The following is a description of a gene set: A protein glycosylation process in which a carbohydrate or carbohydrate derivative unit is added to a protein via the hydroxyl group of peptidyl-serine, peptidyl-threonine, peptidyl-hydroxylysine, or peptidyl-hydroxyproline, or via the phenol group of peptidyl-tyrosine, forming an O-glycan. species: Mus musculus Mouse Gene Set: GOBP_PROTEIN_O_LINKED_GLYCOSYLATION, and this is the list of marker genes: Tmem260, Slc35c2, Poglut3, Galnt11, Galnt1, Fut9, Tmtc4, Fut11, Tmtc3, B3gnt9, Pomt1, Pomt2, C1galt1c1, St8sia6, Galntl6, B3gnt3, Plod3, Vegfb, B3galnt2, Poglut2, B4gat1, Crppa, Ogt, Tet3, Tet1, B3galnt1 (NCBI Gene Id 26879), B3galt6, Fut10, Galnt2, Gxylt1, A4gnt, B3galt5, Galnt15, Galnt12, B3gnt6, Mgat5b, B3gnt4, Galnt5, Galnt14, Large2, Galnt7, St6galnac2, Gcnt3, Galnt17, Pgm3, Galnt9, Galnt6, Eogt, Pomgnt2, B3gnt2, Large1, Gxylt2, B3gnt7 (NCBI Gene Id 329198), Galnt13, Fkrp, C1galt1, Pofut2, Pomgnt1, Galnt16, Galnt10, Xxylt1, Pofut1, Rxylt1 (NCBI Gene Id 66675), B3gnt8 (NCBI Gene Id 232984), B3galt1, Galnt4, Pomk, B3galt9, Tet2, Tmtc2, Fut4, B3galt2, B3glct, Galnt3, Fktn, Trak2, Dpm1, B3galt4, Poglut1, Il15, B3gnt5, Galnt18, Gcnt1, Tmtc1